Given this list of marker genes CRYBA1, CENPH (centromere protein H), CYTH1, MCAM, CLPTM1L, FEZ2, CLDN3, GLUL, MAN2C1, ADD1, BMP8B, PLAAT1, HAUS2, CYP4A11, DAPP1, DNM3, DDC (NCBI Gene Id 9492), ASCC2, HEXB, KCNJ2, EPHA1, KIF1A (NCBI Gene Id 654843), CD84, EXT1, CENPB, BACE1, CKMT2, L2HGDH, LBR, CILK1, HEXA, LY6H, HLF, GABPA, H1-8, LINGO1, AIM2, CCR1, CTDP1, DSTYK, HSPB3, ARHGAP18, DEPDC1, CABP5, ERBB2, ELF1, TPGS1, CYP7A1, CAMK2G, LETMD1, IL12RB2, DYRK3, IDH1, ANKRD46, HSD17B8, CYS1, KDELR1, EFHD2, LRP1B, HES6, ASH1L, ACOT8, ELOVL4, DNAJC18, CYP1A1, BAIAP3, CCDC175, HABP4, CD248 (NCBI Gene Id 57124), DNAJB13, CELF2, FZD2, JAK1, LHX9, ERCC6L2, C1QTNF12, CEND1, DPAGT1, FUCA2, FHL3, KIAA0513, GNA14, DBNDD2, CTDSP2, CDKAL1, MAN1B1 (NCBI Gene Id 51697), BLTP2, DIP2B, DNAJC30, KIF13A, ASZ1, DLL3, MAX, CRYGB, CHCHD6, C11orf52, MBP, CDH17, HOMER2, LTC4S, GPR34, ITGB3, CHST12, FIG4, L1CAM, CIT (citron rho-interacting serine/threonine kinase), AFMID, CUL4A, EGFL6, FXYD4, BPIFB2, GRAMD2B, B3GNT4, ISCU, KLHL42, DUSP9, DCXR, DENND4C, BTBD2, CASQ2, APOBR, ABHD10, ABCB7, ABHD16A, ASAH2, GSC, HSD17B10, SELENOH, CNPY3 (canopy FGF signaling regulator 3), KIF20A, ITIH3, GALK2, CELF4, DERL1 (derlin 1), ACSM2A, ACSL6, COX6B2, ANKZF1, EYA2, FRG1, FITM1, INSL5, LAPTM5, MBD6, BPHL, KCNIP3, LUC7L3, ESRRB, LY6G6C, LIPG, APOM, AHCYL2, GJB3, CXorf38, FCGR1A, FGF2, DDX47, IFT122, TMEM242, CNR2, GRIP1, GSPT2, IFT46, VWA7, ARL3, CDK16, ACAD10, ADM, EMC9 (NCBI Gene Id 95655), ACTN2, ARHGAP12, SMIM11, GRIK5, GML, AGRP, GPR50, KCNJ15, KIF17 (kinesin family member 17), GIMAP6, EPB41, HSPB8, IMMP2L, F5, MAL, FOXO3, CYP4F3, CTC1, CENPF, CCNL1, CD163, ITGB3BP, DCT, ADIPOQ, AP4M1, HDAC5, CDCA3, DDX5, EVI5, MAN2B2, GAMT, here is a description of the gene set: from publication Amit I, Garber M, Chevrier N, Leite AP, Donner Y, Eisenhaure T, Guttman M, Grenier JK, Li W, Zuk O, Schubert LA, Birditt B, Shay T, Goren A, Zhang X, Smith Z, Deering R, McDonald RC, Cabili M, Bernstein BE, Rinn JL, Meissner A, Root DE, Hacohen N, Regev A (PMID 19729616) mouse primary BMDCs were stimulated with tlr ligands and gene expression changes were profiled on Affymetrix arrays studied in species Homo sapiens Human Gene Set: GSE17721_CTRL_VS_CPG_24H_BMDC_UP Genes up-regulated in comparison of control dendritic cells (DC) at 24 h versus those stimulated with CpG DNA (TLR9 agonist) at 24 h.